The following is a description of a gene set: studied in species Mus musculus Mouse Gene Set: GOBP_PROTEIN_K11_LINKED_DEUBIQUITINATION A protein deubiquitination process in which a K11-linked ubiquitin chain, i.e. a polymer of ubiquitin formed by linkages between lysine residues at position 11 of the ubiquitin monomers, is removed from a protein., and this is the list of marker genes: Usp30, Otud4, Otud7b, Tnfaip3, Otud3, Otud6a, Vcpip1, Otud7a, Otub2, Yod1, Usp37